The following is a description of a gene set: Mouse Gene Set: GOMF_TRANSCRIPTION_FACTOR_BINDING species: Mus musculus Binding to a transcription factor, a protein required to initiate or regulate transcription., and this is the list of marker genes: Bcl11a, Trim68, Crtc1, Ddit3, Arrb1, Srf, Nr3c2, Pcna, Apbb1, Ncapg2, Sost, Magea4, Sox17, Nfatc1, Nr4a2, Zfp618, Cdk9, Nlk, Ifi206, Thra, Taf1, Sp1, Nup62, Hcls1, Hoxa7, Nr0b2, Pou1f1, Park7, Kat6a, Phf1, Per3, Pou5f1, Ifrd1 (interferon-related developmental regulator 1), Ski, Nab1 (Ngfi-A binding protein 1), Atoh8, Hdac9, Sry, Creg1, Bloodlinc, Crx, Vdr, Eno1, Runx1t1, Prkdc, H2bc23, Nkx2-2, Cpne1, Wwp2, Dazap2, Chchd2, Pbxip1, Prpf6, Gata1, Id2, Taf10, Eif4e, Anxa4 (NCBI Gene Id 269772), Pgr, Eno1b, Tead3, Dnmt3a, Optn, Nfatc4, Nfia, Exosc9, Hmga1b, E4f1, T, Cdkn2a, Ifi204, Cbx3, Gfi1b, Hcfc2, Tox2, Ncoa3, Ciita, Psma6, D1Pas1, Rbpj, Cebpb (CCAAT/enhancer binding protein beta), Flt3, Smarcb1, Srarp, Stk4, Tacc2, Hdac2, Ube2i, Tcp10c, Chchd2-ps, Apex1, Hdgf (heparin binding growth factor), Eef1d, Med16 (mediator complex subunit 16), Npm1, Arnt (aryl hydrocarbon receptor nuclear translocator), Sox2, Pagr1a, Bbs4, Scx, Cdk5rap3, Dapk3, Commd8 (NCBI Gene Id 97223), Bhlhe41, Esr1, Commd7, Nkx2-5, Bbs10 (NCBI Gene Id 71769), Sting1, Ehmt2, Cnot1, Brd8, Hif1a, Pias2, Kpna2, Lrif1, Med30, Edf1, Hdac8, Nr5a2, Gcm1, Dact2, Tcp10b, Uimc1, Bud31, Cdc5lrt5, Gtf2a2, Cbx5 (chromobox 5), Brd7, Rnf14, Fos, Hif1an, Ifi203, Kat2b, Dgkq, Foxh1, Ncoa6, Esrrb, Sox9, Tal1, Ankrd2, Hcfc1, Tfam, Ercc1, Wfs1, Hnrnpu, Ptpn2, Lrp2, Zbtb8a (NCBI Gene Id 73680), Ncor1, Tbx2, Gtf2h1, Ifi208, Usf2, Kdm5d, Hdac3, Nlrp3, Trp53bp2, Kat8, Taf4b, Kdm4c, Hsd17b10, Mtdh, Magea3, Mdfi, Pbx2, Ddrgk1, Kat2a, Magea2, Mixl1, Nfkbia, Ptprn, Uba3, Setd3, Phf12, Ifi214, Prrx1, Tbx6, Pparg, Smad2, Kdm3a, Nr3c1, Nr1d1, Mtor, Fbl, Nr4a3, Prox1, Meis2, Mecr, Rfc1, Daxx, Bbs7, Bcl3, Nr4a1, Stat6, Nab2, Taf9, Gtf2i, Six1, Rad21, Eomes, Rb1, Polr1e, Rorc, Runx3, Cand1, Brf2, Dact1, Nrip1, Hnf1a, Lats1, Hhex, Zfpm2, Usp11, Lpin1, Ets2, Foxo1, Map3k10, Gata4, Lmo3, Tcf15, Cd34 (CD34 antigen), Rnf6, Atf4, Prdm13, Rara, Gata2, Trappc2, Baiap2, Zbtb49, Nolc1, Psmc2, Ccnt2, Smarcd3, Parp1, Hmga1, Spen, Zfp366, Slc30a9, Add1, Paxbp1, Ikzf4, Tbx3, Myod1, Lmo1, Mecp2, Nr1h3, Bex2, Drap1, Ifi27, Id3, Ascl2, Rora, Parp9 (NCBI Gene Id 80285), Vhl (von Hippel-Lindau tumor suppressor), Kat5, Sumo1 (NCBI Gene Id 22218), Prmt2, Tdg, Arid5a, Icmt, Hmga2, Tmf1 (NCBI Gene Id 414107), Hoxc13, Ctnnb1, Brms1, Hand1, Cry1, Brf1, Csrp3, Sra1, Dcp1a, Nr1i2, Nif3l1, Nfkbid, Med13, Pax3, Bbs5, Spi1, Foxa1, Nr5a1, Ddx5, Bbs1, Lmo4, Stat1, Ubn1, Tbx18, Taf4, Stat5b, Med25, Ywhah, Sall4, Lmo2, Mtf2, Grhl1, Fam89b, Sin3a, Dmap1, Ppard, Rbbp8, Rxra, Ywhaz, Bsn, Arnt2, Tob2, Fus (fused in sarcoma), Dusp26, Actn4, Ifi207, Aip, Eed (embryonic ectoderm development), Sp3, Thrap3, Hes1, Bmyc, Rarg, Irx5, Gtf2e2, Snw1, Naaa, Rps6ka1, Smarca1, Tcf12, Chd4, Gata6, Bcas3, Hspa1b, Sp100, Trib1, Sik1, Ctcf, Nfya, Taf12, Pbx1, Isl1, Ctbp2, Pim1, Bhlhe40, Sub1, Foxo4, Lef1, Noc2l (NOC2 like nucleolar associated transcriptional repressor), Magea10, Foxc1, Smad3, Asah1, Dhrs7b, Klf1, Ifi211, Fbp1 (fructose bisphosphatase 1), E2f1, Med12l (NCBI Gene Id 99835), Chd6, Zfp296, Cdc5lrt6, Mkks, Crtc2, Grhl2, Mef2d, Med6, Ifi205, Ipo13 (importin 13), Cdc37, Sox10, Calr, Jund, Figla, Hr, Znhit6 (NCBI Gene Id 69746), Rarb, Ppid, Wiz, Med1, Ncor2, Hmgb2, Sufu, Myc, Dcaf1, Mapk14, Ahr, Utf1, Grm1, Mta2, Suz12, Hdac4, Rpl23, Ctbp1, Bdp1, Csnk2b, Klf14, Foxl2, Bptf, Arid2 (NCBI Gene Id 77044), Uba2, Sdr16c5, Nfatc3, Ighmbp2, Padi2, Pitx2, Lhx2, Rela (NCBI Gene Id 19697), Dhx33, Flywch1, Nrbf2, Cxxc5, Dnaaf4, Nanog, Stat5a, Tcf21, C1qbp, Ttc8, Mdfic, Tle4, Tada3, Asxl1, Srebf1, Mta1, Ifi203-ps (interferon activated gene 203, pseudogene), Gmnn, Pik3r1, Pura, H2bc24, Arap1, Msx2, Kdm5c, Fhl2, Trp53bp1, Hdac7, Crtc3, Elk1, Dot1l, Dnaja3, Cggbp1, Hey1, Med12, Hspa1a, Sall1, Bex1, Zbtb17, Tbp, Stat3, Pclo, Mkx, Gabarapl1, Ldb1, Tpt1, Tead2, Mettl23, Strn, Notch2, Ncoa7, Sorbs3, Dnaja1, Prdm16, Yeats2, Cand2, Ptprt, Tbx20, Faf1, Nfyb, Med17, Mef2c, Tert, Mndal, Zfp516, Gata3, Mef2a, Irf2bp1, Eaf1, Per1, Thrb, Kdm1a, Psmc5, Trim6, Dcaf13, Src, Tcp10a, Med24, Nkx3-1, Keap1, Pramel13, Ankrd42 (NCBI Gene Id 73845), Cdc5l, Lyar, Ruvbl1, Cebpa, Nr1h2, Jarid2, Cdc5lrt9, Vgll4, Tbx5, Ehmt1, Rad23b, Hdac6, Epas1, Wbp2, Taf6, Per2, Ddx54, Pitx1, Parp10, Ptma, Pdcd11, Bbs2 (NCBI Gene Id 67378), Klf5, Hsf1, Ezh2, Mad2l2, Yap1, Psmc3ip, Foxf2, Tgfb1i1, Ppargc1a, Cnot7, Ifi213, Taf11 (NCBI Gene Id 68776), Kctd1, Foxp3, Rxrb, Nr0b1, Stk36, Max, Cdc5lrt10, Hspb1, Ankrd1 (ankyrin repeat domain 1), Bmal1, Dnmt1, Pax2, Atf7, Ppargc1b, Creb1, Rbfox2 (NCBI Gene Id 93686), Purb, H2bc9, Zfp653, Ubxn7, Hira (histone cell cycle regulator), Nfe2l2, Cit, Six3, Trim11, Trim24, Ep300, C1d, Uhrf2, Kmt2a, Akap8, Nek6, Tcf4 (NCBI Gene Id 67762), Creb3, Gtf2f1, Arid1a, Prdm5, Snf8, Setd1a, Trerf1, Egr2, Pou4f1, Jun, Nsd1, Nbn, Cenpf, Ifi209, Tle1, Elob, Zfpm1, Nucks1, Lhx3, Dtx3l, Psmc1, Tcf3, Trp53 (transformation related protein 53), Hand2 (heart and neural crest derivatives expressed 2), Hipk2, Map3k7, Zbtb43, Foxp1, Sirt1 (sirtuin 1), Rbx1-ps, Cdc5lrt7, Zfp473, Ccnt1, Tfdp1, Rps3, Fam220a, Psip1, Ascl5, Gtf2a1, Fiz1, Ddx20, Naca (NCBI Gene Id 404597), Camta2, Sox8, Zbtb7a, Mlxipl, Med4, Twist1, Setd6, Commd6, Trip12, Gtf2b, Psmd10, Yy1, Gbx2, Taf7, Zfp644, Pkn1, Atf2, Trappc2b, Gsc, Hnrnpf, Ddx3x, Rnf4, Crebbp, Hnf4a, Nr1h4, Runx1, Cdc5lrt1, Mms19, Rest, Jup, Actb, Tcf23, Tacc1, Wipi1, Spop, Xpc, Tcf7l2 (NCBI Gene Id 21416), Ets1, Dr1, Magea5, Smarca4, Hdac1, Six2, Zbtb16, Neurod1, Atxn3 (ataxin 3), Cdc5lrt8, Id4, Sirt2, Gsk3b, Pias1, Ar, Usf1, Mapk3, Nfatc2, Bcl2, Cnot2, Tcerg1, Trp73, Eloc, Ruvbl2, Psmd9, Smarce1, Hnf1b, Bcor, Hdac5, Cry2, Trip4, Smad4, Lcor, Ebf4, Nhlh2, Fkbp4, Ppara, Sumo2, Runx2, Taf13, Klf4, Ascl1, Zfp703, Hes6, Cited2, Pax6, Foxp2, Ctdp1, Nop58, Satb1 (NCBI Gene Id 70334), Trib2, Mlx, Clock, Ercc4, Hey2 (NCBI Gene Id 30802), Dhx9, Crkl, Prkcb, Zfp568, Ncoa2, Dll1, Hmgb1, Bcl6, Bcl10, Thap7, Twist2, Htt, Txlng, Xpo1, Myocd (NCBI Gene Id 214384), Rbx1, Foxo3, Rnf25, Hspa4, Hdac11, Ncoa1, Flna, Cdc5lrt4, Fem1a, Cebpg, Nkx2-1, Ccdc62, Sri